The following is a description of a gene set: Human Gene Set: REACTOME_SCF_BETA_TRCP_MEDIATED_DEGRADATION_OF_EMI1 species: Homo sapiens SCF-beta-TrCP mediated degradation of Emi1, and this is the list of marker genes: PSMB3, PSMC6, PSMD6, PSMD1, PSMA6, PSMD7, PSMA4, CDC20, PSMD14, PSMB6, PSMB4, PSMC4, PSMA1, FZR1, BTRC, SEM1, PSMC3 (proteasome 26S subunit, ATPase 3), PSMA7, PSMC1, SKP1, RPS27A, PSMD11, PSMD2, PSMD3, PSMA5, PSMC2, PSMD12, PSMC5, PSMD13, FBXO5, PSMB7, UBB, PSMB1, CUL1, PSMA2, ADRM1, UBC, PSMD8, PSMB5, PSMB2, UBA52, PSMA3